The following is a description of a gene set: part of: Metabolism of amino acids and derivatives Reactome Pathway: Phenylalanine and tyrosine metabolism This event has been computationally inferred from an event that has been demonstrated in another species.<p>The inference is based on the homology mapping from PANTHER. Briefly, reactions for which all involved PhysicalEntities (in input, output and catalyst) have a mapped orthologue/paralogue (for complexes at least 75% of components must have a mapping) are inferred to the other species. studied in species Mus musculus electronically inferred by orthology from the curated human pathway, and this is the list of marker genes: Pah, Fah, Gstz1, Asrgl1, Hpd, Pcbd1, Tat, Hgd